Given this list of marker genes LRRK2, FEN1, TFPT, SYT5, INO80E, BMF, CDC42, ARF6, CDK2, DCN, EPHA1, LMAN1, CAPG, SORBS3, PIP4K2A, SERPINF2, HRK, C15orf62, CCN2, SYNJ1, WIPI1, SEPTIN7, STRA8, MAPK9, DDHD1, PLD6, DLGAP5, SDCBP, ERC2, BTC, RHOA, ABI2, PFN3, CDC23, FHOD1, ANAPC7, MAPT, TESK1, RAPGEF3, CDC42EP3 (NCBI Gene Id 10602), BMP10, CEP135, DRG1, SYT11 (NCBI Gene Id 92303), SYT9, LIMK1, SNX4, UBAP2L (ubiquitin associated protein 2 like), NFRKB, ANAPC11, FCHSD2, CDK1, ITGB1BP1, NAF1, SH2B1, PIWIL2, ZNRF2, CX3CL1, CLIP1, EGF, HOXA13, FUZ, SYNPO2, MRE11, TOGARAM1, SYNPO2L, LMOD1, LRP5, BAIAP2L1 (BAR/IMD domain containing adaptor protein 2 like 1), SNX7, ATR, CNOT6L, PROX1 (NCBI Gene Id 5629), SPHK1, CCDC15, BNIP3, SLF1, NCAPG, ARHGEF10L, ARHGEF15, IFT20, MAP3K4, YY1, FYCO1, BRAF, PNKP, NCAPD3, SPAG5, SNX18, TNF, HSPA1A, PPP1R10, CDC42EP2, DAZL, GPR65, HSF1, ADD3 (NCBI Gene Id 121), GPER1, ELAPOR1, SPAST (NCBI Gene Id 6683), NUMA1, DOC2A, ZNRF1, INO80, SSBP1, CDC20, FAM162A, MIR1-1, PAN3, RTEL1, UVRAG, MCRS1, RAC1, SLAIN2, BIK, LIMCH1, CFL2, BAIAP2, MTOR, SAXO1, KATNB1, NBN, AKAP9, CDC42EP4, DZIP1, KCTD17, NAV3, PRRT2, STX18, CCL24, SLX4, PRKCE, ALOX15, P2RX7, CCL26, TNFSF10, NCAPG2 (NCBI Gene Id 54892), TACR1, PRAP1, HNRNPD (heterogeneous nuclear ribonucleoprotein D), WNT5A, MLST8, KATNBL1, MNS1, IRGM, PYCARD, SYT2, IGF1, APOA1, CCR7, KDR, ADCK1, INO80D, SIRT2, RPS3, CCT4, SFRP1, RALA, CARMIL1, ANK1, SYT3, FSCN1, ZDHHC6, CCDC88A, PFDN2, DMRT1, CNOT6, SFPQ, DCTN1, SKA3, RB1, SKA1 (NCBI Gene Id 220134), DRD3, NCAPD2, PLK4 (NCBI Gene Id 27119), RAD21, SDC4 (NCBI Gene Id 6385), ATG2A, CENPJ, TRIM27 (NCBI Gene Id 5987), BAD, TCP1 (NCBI Gene Id 6950), SHCBP1L, TERF2, INSR (NCBI Gene Id 3643), CROCC, PLAUR, ARHGAP35, TAPT1, PPM1E, MARCHF5, KLF4 (NCBI Gene Id 9314), CTTN, MYOC, POC1B, FCHSD1, SYT1, WHAMM (WASP homolog associated with actin, golgi membranes and microtubules), RUVBL1, TERF2IP, GSK3B (glycogen synthase kinase 3 beta), PDCD6IP, TINF2, ERCC1, ACTR8, SYNPO, UBE2C, SRC, MFF (mitochondrial fission factor), BCL2L11, MEIOSIN, RHOC, NUP62, GRN, SMC4, INS, VIL1, AMOT, CCT6A, NCKAP1L, CD28, TTBK2, CCT7, WASF2, PIP4K2B, NCK1, SNX9 (sorting nexin 9), MYC, C2CD5, LMOD2, DKC1, F2RL1, BUB1, TPR, NVL, DLG1, RUVBL2, PKIB, WRAP73, PDE4DIP, CKAP5, UCHL5, CCT5, WDR1, ARHGEF5, RALBP1, WASHC2C, IFT88, UBE2B, RAB3GAP1, GIT1, PRKN, PMAIP1, EPGN, CUL3, TGFA, ANKRD53, NABP2, MICU1, TGFBR1, MAD1L1, BOK, IL5, WRAP53, AURKB, PHIP, LCP1, KAT5, MIEF1 (mitochondrial elongation factor 1), SMC5, FES, AURKA, FLNA, NPR2, OSBP, STIL, MUL1, PIP4K2C, FBXO4, SCIN, RGCC, CTNNB1, TRIM32 (NCBI Gene Id 3971), HNRNPA1, MTSS1, CD47, IL1B, CCT8, SASS6, NF2, LNPK, MECP2, WDR45, MCU, NEK2, ANAPC5, CDC42EP5, RICTOR, SH3GLB1 (NCBI Gene Id 51100), MCOLN1, SYT7, TOM1, CCL21, SPIRE1, FERMT2, TMED9, TP53, TNKS2, HAP1, ATG5, OOEP, OCLN, FGF8, HIP1R, NPHS1, PLA2G5, CEP295, EVL (Enah/Vasp-like), FER, ARPC2, RPH3AL, RPH3A, DDHD2, EDN1, MSX1, ESPL1 (NCBI Gene Id 9700), MAP2K7, ATMIN, LIG4, DSTN, BECN1, CAPRIN1, CRACD, RAB11FIP3 (RAB11 family interacting protein 3), MIEF2, CDK5R1, NCKAP1, SEPTIN9, ANXA1, MAP1B, SNX30, NES, NCK2, PTGES3, TRPV4, ZNF205, CDC16, IL1A, NCAPH, NCAPH2, BIN1, PINK1, PDXP (NCBI Gene Id 57041), SMCR8, GSK3A, RAB3GAP2, VASP, DNM1L, POT1, MAPK3, GNL3, GSN, SMC2, CDK5RAP2, PXN, CCL11, ATRX, SURF4, MSTO1 (misato mitochondrial distribution and morphology regulator 1), SMAD3, CAV3, PDGFRB, RP1, BRK1, MAPK1 (NCBI Gene Id 5594), TNKS, MAPK15, MOAP1, SLF2, SDC1, IGF2, ACTN2, STMN2, SYT4 (NCBI Gene Id 6860), MSX2, CCP110, PGAM5, YME1L1, WASF3, TPM1, VPS35, MAPKAPK5, ATM, S100A10, ENTR1, CCT2, SLAIN1, MAD2L1BP, HNRNPA2B1 (NCBI Gene Id 3181), ABL1, ULK1, BAG4, DHX36, FIS1, LRSAM1, CEP120, CSF3, ANXA2, HCK, PLCB1, DYNC1H1, PFN1, PPM1F, ARHGEF10, SYT8, LPAR1, CFL1, HTT, PDGFB, MLLT11, WASF1, NRP1, CLASP1, SWAP70, GRB2, HSP90AA1, ACTL6A, ENDOG, MMP9, PRKD1, ROCK2, CYFIP1, BBS4, ATP5IF1, SEMA5A, GPSM2, RALB, NEK7 (NCBI Gene Id 148565), TGFB3, SLX1A, PRKCQ, SLX1B, DDX11, CARMIL2, PSRC1, CHCHD10, INO80B, PRDM9, PTK2B, NUSAP1, INO80C, ACTR5, BBC3, ADRB2, PPP3CB, ARL2, PARN, ZMYND10, MET, RAD51AP1, PLXNA3 (NCBI Gene Id 8276), NSMCE2, CDKN1B, CSF2, EDN3, EREG, CNOT1 (CCR4-NOT transcription complex subunit 1), BAX, BID, TAL1, MYLK3, SIRT6, PLEK, HSPA1B, TERF1, BAIAP2L2, PML (PML nuclear body scaffold), MAGEL2, PFN2, SYT13, TAC1, PAN2, WNT4, MAPRE1, CCT3, MSN, DOC2B (double C2 domain beta), CDC42EP1, ACD, SMPD3, PPP1R35, TENM1, SNCA, MARK4, CALCOCO2, NPM2, CNOT2, PAK1, MACROH2A1, SIVA1, KIRREL1, VPS4B, RAD50, BAK1, here is a description of the gene set: Any process that increases the frequency, rate or extent of a process involved in the formation, arrangement of constituent parts, or disassembly of an organelle. species: Homo sapiens Human Gene Set: GOBP_POSITIVE_REGULATION_OF_ORGANELLE_ORGANIZATION